The following is a description of a gene set: Reactome Pathway: Glucagon signaling in metabolic regulation part of: Integration of energy metabolism species: Homo sapiens Glucagon and insulin are peptide hormones released from the pancreas into the blood, that normally act in complementary fashion to stabilize blood glucose concentration. When blood glucose levels rise, insulin release stimulates glucose uptake from the blood, glucose breakdown (glycolysis), and glucose storage as glycogen. When blood glucose levels fall, glucagon release stimulates glycogen breakdown and de novo glucose synthesis (gluconeogenesis), while inhibiting glycolysis and glycogen synthesis.<br>At a molecular level, the binding of glucagon to the extracellular face of its receptor causes conformational changes in the receptor that allow the dissociation and activation of subunits Gs and Gq. The activation of Gq leads to the activation of phospholipase C, production of inositol 1,4,5-triphosphate, and subsequent release of intracellular calcium. The activation of Gs leads to activation of adenylate cyclase, an increase in intracellular cAMP levels, and activation of protein kinase A (PKA). Active PKA phosphorylates key enzymes of glycogenolysis, glycogenesis, gluconeogenesis, and glycolysis, modifying their activities. These signal transduction events, and some of their downstream consequences, are illustrated below (adapted from Jiang and Zhang, 2003)., and this is the list of marker genes: ADCY9, ADCY7, GNAS, GCGR, ADCY3 (NCBI Gene Id 9608), ADCY4, GNG11, PRKAR1B, GNG7, GNG4, GNG5, PRKAR2A, GNG12, PRKACG, PRKACA, GNB2, PRKAR1A, ADCY6, ADCY2 (adenylate cyclase 2), PRKACB, GNG3, ADCY8, GNG10, GNG2, PRKAR2B, GNG8, GNB1, GNG13, GNB4, ADCY5, GCG, ADCY1, GNB3